The following is a description of a gene set: species: Homo sapiens A narrowing of the orifice of the tricuspid valve of the heart. Tricuspid stenosis Human Gene Set: HP_TRICUSPID_STENOSIS, and this is the list of marker genes: RPS19 (NCBI Gene Id 8378), ADAMTSL2, PLD1, CHST3, MYCN, FBN1